Given this list of marker genes MCM6, RBX1, GINS4, CDC45, MCM3, UFD1, MCM4, MCM5, GINS1, PIF1, CUL2, ELOC, GINS3, MCM2, NPLOC4, VCP, LRR1, GINS2, ELOB, MCM7, UBB, here is a description of the gene set: Pathway Definition from KEGG: CMG+PIF1 -> CMG+CRL2-LRR1 -> CMG == MCM7+Ub -> MCM7+VCP+UFD1+NPL4 DNA replication termination. Pathway ID: N01473. Pathway type: Reference. Pathway class: nt06509 DNA replication. Human Gene Set: KEGG_MEDICUS_REFERENCE_DNA_REPLICATION_TERMINATION studied in species Homo sapiens